Given this list of marker genes RGS8, JARID2, SNX18 (NCBI Gene Id 112574), CEP170, SIX4, SOBP, RFPL2, EPHA5, TNRC6B, BAZ2B, POLH, MAPRE1, M6PR, IGDCC4, FIGN, MAP4K4, CLCC1, XRN1, UBE2I, RPS6KA5, MAPKBP1, TRMT10A, MAP3K7, BCL2L11, NR2C2, CRK, BDNF, SDC1, ZNF367, MLLT10, TFAP2C, GTF2H1, CRLF3, SPAG9, RB1CC1, TBX5, ACTG1, CLEC2B, BLOC1S5, GATA6, PCDH10, KCNA6, BICD2, PRRT3, BAZ1B, EPHA8, RAP2A, CNOT6, RNF112, ZMYND11, TIAM1, RTN4R, INO80D (NCBI Gene Id 54891), LRRC8B, KLHL29, TFRC, ZNF660 (zinc finger protein 660), E2F7, SNX4, HOXD10, TRIM2, CSRNP3, MDGA2, ELOVL2, KCNA1, PLA1A, LGALSL, CREB1, EBF2, LCA5, TSPAN33, NCOR2, CSMD1, NR5A2, NR4A3, CDK6, BBX, GALNT1, ARK2C, SON, LRRC17, CCNB3, CNIH4, CEP350, PAX1, GABRB2, SMAP1, HAS3, NR6A1, HOXA3, WNT9B, CADM2, HERC6, LIX1L, KLF4, RPRD1A, LRP12, RORA (RAR related orphan receptor A), CAMK2B, ZBTB6, ARSK, POP1 (NCBI Gene Id 23044), PATL1 (NCBI Gene Id 219988), here is a description of the gene set: from publication Chen Y, Wang X (PMID 31504780) studied in species Homo sapiens Genes predicted to be targets of miRBase v22 microRNA hsa-miR-10a-5p, hsa-miR-10b-5p in miRDB v6.0 with MirTarget v4 prediction scores > 80 (high confidence targets). Human Gene Set: MIR10A_5P_MIR10B_5P